The following is a description of a gene set: Atrophy/Degeneration involving the corticospinal tracts species: Homo sapiens Human Gene Set: HP_ATROPHY_DEGENERATION_INVOLVING_THE_CORTICOSPINAL_TRACTS, and this is the list of marker genes: TBK1, PLP1, BUD23, GTF2I, LIMK1, FKBP6, UBAP1, NEFH, GTF2IRD2, SQSTM1, SPG7, SPG11, NIPA1, FUS (NCBI Gene Id 406232), BAZ1B, TMEM270, SOD1, CHCHD10, TBL2, GTF2IRD1, RTN2, STX1A, ATL1, WASHC5, CPT1C, KPNA3, ABCD1, PRPH, NCF1, DCTN1, MT-ATP6, ELN, METTL27, EIF4H, VCP, TARDBP, VPS37D, CLIP2, RFC2, DNAJC30, SLC33A1, SPAST